Given this list of marker genes SMUG1, OGG1, NEIL3, MBD4, MUTYH, MPG, NTHL1, ERCC5, UNG, NEIL1, NEIL2, TDG, here is a description of the gene set: The formation of an AP site, a deoxyribose sugar with a missing base, by DNA glycosylase which recognizes an altered base in DNA and catalyzes its hydrolytic removal. This sugar phosphate is the substrate recognized by the AP endonuclease, which cuts the DNA phosphodiester backbone at the 5' side of the altered site to leave a gap which is subsequently repaired. species: Homo sapiens Human Gene Set: GOBP_BASE_EXCISION_REPAIR_AP_SITE_FORMATION